The following is a description of a gene set: species: Homo sapiens Abnormality of the oral mucosa. Human Gene Set: HP_ABNORMAL_ORAL_MUCOSA_MORPHOLOGY Abnormal oral mucosa morphology, and this is the list of marker genes: COL7A1, AFF3, DKC1, SLC17A5, VPS37D, BANK1, MEFV (NCBI Gene Id 4210), ITGA6, CD27, MAP1B, KCNJ6, TMCO1, TMEM270, B4GALT7, TERT, IGHG1, NAGA, BRAF, FBXO28, PRMT7, USB1, BLK, GJB6, GPC3, IL10RA, ZNHIT3, JAK2, CEBPE, GORAB, IL23R, EVC, KRT5, FGA, RORC, CDKN2B, DNAJC30, CAST, ACD, GP9, RNF125, ITGAM, SRP19, MBTPS2, BUD23, NOD2, SATB2, ZAP70, DNASE1, PRKACB (NCBI Gene Id 5567), VPS13B, TNFSF4, LIMK1, PLEC, TBL2, BAZ1B, LAMB3, FAS, NOTCH3, ETS1, NCF1, NRAS, SC5D, GDF2, GLI1, COL17A1, SLC46A1, STK4, NLRP3, PIGN, LBR, CTSC, IRF5 (interferon regulatory factor 5), JAZF1, DNM1, RALGAPA1, ELOVL4, SPP1, ITK, FCGR2B, IRAK1, MYD88, CASP10, ABCD1, DYNC2LI1, FYB1, USP9X, EMC1, NCF2, PIGA, NFIX, CYBA, XYLT1, PRF1 (NCBI Gene Id 5551), ROR2, TSC2, NEU1, ERAP1, GJB2, RARA, KRT14, CARMIL2, SCARB2, GBA1, KCNN3, CD96, PRKACA, CAT, CLPB, SLC19A1, SMAD4, METTL27, LMNB1, TBCK, DHCR7, TINF2, NTRK1, KCNH1, SLC37A4, KLRC4, ELN, NKX6-2, MTX2, KIF23, KRT6B, TRIM8, FGFR2, CD40LG, SAMD9, UBE2L3, PML, PRKAR1A, FIP1L1, IL17RC, FIG4, PDCD1, DVL1, ZBTB16, ABCC9, EXTL3, EDA, DDR2, IL12A, MGAT2, KRT6A, ELF4, TSC1, RMRP, IL6 (interleukin 6), CTLA4, PERP, STAT3, WRAP53, MIA3, RIPK4, VAC14, F2, TREX1, HPS3, IDS, ADAMTS3, IL7R (NCBI Gene Id 3575), RTEL1, WDR26, SAA1, WIPF1, SETBP1, CR2, FAM20C (FAM20C golgi associated secretory pathway kinase), WDR1, ANTXR2, MMP14, ECM1, CLTRN, ELMO2, STAT5B, MYSM1, GTF2IRD1, CDKN1A, SOS1, GNPTAB, IL18BP, TICAM1, GLMN, ORAI1 (ORAI calcium release-activated calcium modulator 1), NOTCH2, CLIP2, NPM1, MVK, BLOC1S5 (NCBI Gene Id 63915), RIN2, RHOH, SH3PXD2B, NXN, FCGR3B, HLA-B, MMACHC, FZD2, OSTM1, EVC2, TLR7, GUSB, TBL1XR1, LMBRD1, MMP2, PRKDC, ATRX (ATRX chromatin remodeler), NR3C1, SLC35C1, F13A1, FKBP6, DHCR24, SERPINF2, SYK, TP53, LAMC2, ACVRL1, NABP1, G6PC3, MECP2, PXK, WNT5A (NCBI Gene Id 7474), AGA, F7, BCOR, SREBF1, MAP2K1, TCTN3, CDH23, CCR1, TRPV3, ASXL3, FERMT1, ATG7, DNAJC21, USP8, SLC6A19, IRF2BP2, KRT6C, ZEB2, ALMS1, PLAGL1, SAT1, CCBE1, NUMA1, GLB1, COL3A1, KCNK4, USP48, CDKN1B, RELA, RHBDF2, TBC1D24, CYBB, BLOC1S3, C4A, IER3IP1, SBDS, F5, CNTNAP1, NCF4, PLG, C1S, FGG, F8, DSP, MMP1, STX1A, GTF2IRD2, KCNMA1, TLR4, ELANE, FAT4, TNIP1, SEC61A1, IRF9, SASH3, ATP6V1B2, LAMA3, GNAQ, DCLRE1B, FCGR2C, KRT4, IL10, KYNU, PTPN22, F13B, ADAMTS2, XYLT2, TERC, PDGFRB, MCFD2, NLRP12, AP3B1, IFNG, ADA2, WAS (WASP actin nucleation promoting factor), IDUA, TNFAIP3, IFNGR1, KRT16, AEBP1, HIVEP2, PIGS, IL21, ENG, RFC2, IL12A-AS1, ABCC6, RACGAP1, RIPK1, NHP2, ABCA5, KIF7, UBAC2, HYMAI, CTC1, ANKH, DCLRE1C, C4B, PARN (poly(A)-specific ribonuclease), GCGR, GALE, KIAA0319L (NCBI Gene Id 79932), SLC29A3, C1R, GP1BB, STK11, PLCG1, GP1BA, MAN2B1, TYMS (NCBI Gene Id 7298), EFL1, ITGB2, BGN, AIMP2, GFI1, HLA-DQB1, PLEKHM1, GTF2I, TBC1D2B, ITGA2B, HYOU1, NGF, KRT17, RPA1, STAT4, HLA-DRB1, DSG3, TWIST2, TCIRG1 (NCBI Gene Id 8845), FGB, F10, GPC4, CDKN2C (cyclin dependent kinase inhibitor 2C), FASLG, INSR, FAM20A, REST, MALT1, DVL3, IL1RN, DOCK11, LMAN1, GCSH (NCBI Gene Id 2653), TGDS, TLR8, HYLS1, EIF4H, LYN, HPS1, NOP10, HLA-DQA1, ITGB3 (NCBI Gene Id 3690), ITGB4, CXCR4, OCRL, LYST, C1QB, FGF3, CYBC1, MEN1